Given this list of marker genes ANXA1, TNFRSF13C (TNF receptor superfamily member 13C), LEP, ZNF335, CSF2, MEF2C, KITLG, ATAD5, NMBR, NR5A2, NCKAP1L, IL21, IGF2, ICOSLG, TAC1, TLR4 (toll like receptor 4), HLA-DPA1 (major histocompatibility complex, class II, DP alpha 1), SHH, GPR183, IL1A, TNFSF13B, CD55 (NCBI Gene Id 1604), AIF1 (allograft inflammatory factor 1), EPHB2, IGFBP2, CD3E, MPL, CCL5, MIR181B1, NCK1, RIPK2, OCSTAMP, HLA-DMB, TIRAP, FCRL3, HLA-E, GPAM, PRLR, TLR9, CD276, CD4, CD28, IL12RB1, PNP, TCF3, FLT3LG, HAVCR2, RAC2, PRKCQ, ADA, CHRNB2, TYK2, BCL6, IL18, HHLA2, MIF, CSF2RA, TNFSF9, CD80, BCL2, CSF2RB, IL13, NCK2, BMI1, ZAP70, CSF1, CD6, CORO1A, IL12A, TICAM1, BCL2L1, VAV3, DNAJA3, SLAMF1, FOXP3, IL2, JAK2, CSF1R, CCR2, VTCN1, ZP4, CCL19, CD320, TFRC, IL15, CD38, FGF10, LILRB2, MAPK1, TACR1, NFATC2, XCL1, MIR21, LYN, IL23A, BTK, EPO, BST2, CDKN1A, IL5RA, TRAF6, TMIGD2, BST1, STAT5A, VCAM1 (NCBI Gene Id 7412), TNFSF13, RASAL3, ZP3, HLA-A, CD1D, PPP3CA, CARD11, IL6, FADD, HES1, IL7, CD81, IL6ST, PTPRC, CD209, EBI3, MIR30B, LGALS9, AGER, IGF1, CD46, RPL13A (NCBI Gene Id 94020), WNT3A, PTH, IRS2, DHPS, RPS3, IL2RA (NCBI Gene Id 3559), TNFRSF4, CD24, CLCF1, TGFBR2, CD274, SYK, CD40LG, IL4, PELI1, CD40, IL5, HMGB1, SLC39A10, PTK2, NMB, SLC7A1, CD70, TNFSF4 (NCBI Gene Id 7292), BTNL2, IL12B, SPTA1 (NCBI Gene Id 6708), CD74, SPN, STAT5B, HLA-DPB1, EFNB1, IL23R, CLECL1P (C-type lectin like 1, pseudogene), SASH3, CCDC88B, SELENOK, MYD88, IL1B, FCGR3A, PYCARD, KIT, PDCD1LG2, CD86, MAPK3, IL34, here is a description of the gene set: studied in species Homo sapiens Any process that activates or increases the frequency, rate or extent of leukocyte proliferation. Human Gene Set: GOBP_POSITIVE_REGULATION_OF_LEUKOCYTE_PROLIFERATION